Given this list of marker genes SLC29A3, RAB31, SNHG32, SCD, TNFSF13, AKR1A1, CAPG, RNASE1, ITGB2, CYFIP1, QSOX1, MAN2B1 (NCBI Gene Id 4125), CHST15, C1S, ENPP2, ITGAM, LILRB4, PIK3IP1 (NCBI Gene Id 113791), ENG, CCL18, RBM47, QPRT, BCAP31, KRT2, PMP22, KMO (kynurenine 3-monooxygenase), CYP1B1, AVPI1, CCL13, HK3, FGL2, ACVR1B, TSPAN4, NR1H3, SMARCD3, ASPH, GALNT12, CTBP2, HCK, RGL1, IFI30, HLA-DMB, CREG1 (NCBI Gene Id 8804), ZNF22, TMEM51, SLC2A6, SLAMF8, TNS3, FGR, LY96, CAT, CTSL (cathepsin L), OSBPL1A, FCGR2C, CD63, CYP27A1, TM6SF1, CHN2, LPL, FPR3, RASGRP3, C1QA (NCBI Gene Id 712), LAMC1, TBC1D1, KIAA0930, APMAP, IGSF6 (immunoglobulin superfamily member 6), NLRP3 (NLR family pyrin domain containing 3), CTSC, ITSN1, PLAU, FZD2, ARHGEF10L, CTSB, S100A8, TCN2, FTL, CRABP2, CDKN1A, IDH1, ACSL1, SPP1, SLC31A2, FKBP9, GRN, CD14, GFOD1, LHFPL2, GPX1, RAB13, FADS1, PYGL, CEBPA, SLC27A3, INHBA, HLA-DRA, PLA2G1B, ITGAX, RTN1, SIGLEC9, CCR1, GLUL, S100A9, SPARC, EFHD1, ANPEP, TREM2, SIRPA, TFEC, SLC38A6, SLC7A7, AHCY, CYP7A1 (NCBI Gene Id 1581), FUCA1, LIPA, BLVRB, CSF1R, C1QB, PLXND1, MAOA, TAF4, TMEM176B, PILRA, NPC2, LAMP2, VAT1, ADORA3, C2, PAPSS2, PDGFC, APBA2, TSPAN3, SLC20A1, RIPK2, GSN, AK5, CLEC10A, AQP9, RHOQ, ARHGAP22, SCPEP1, RNF144A, ABCB4, CD9, FCGRT, TFPI, TYROBP, MAP2K6, H2BC12, APLP2, TLR1, FCGR2A, APOC1, SHTN1, C1orf54, HMOX1, CTSA, BACE1, ITGB5, FBP1, MERTK, CEBPB, ST14, LPAR6 (NCBI Gene Id 10161), STOM, PLEKHB1, TIMP2, CLEC7A, TGFBR1, STEAP3, MNDA, MRC1, PLBD1, MPZL1, LMNA, PPFIBP2, SORT1, TUBB6, CTSZ, ACOT7, MS4A4A, ECHDC3, NRP1, FABP4, RNF130, CA2, NAGA, MYOF, CD163, PALLD, LGR4, GLA, SYK, CD33, PSAP, SLC15A3, TP53I3, CD86, PLPP3, LDLRAP1, here is a description of the gene set: from publication Prots I, Skapenko A, Lipsky PE, Schulze-Koops H (PMID 21347372) Genes down-regulated in comparison of CD25+ regulatory T cell (Treg) treated with IL4 at day 10 versus CD25- T cells treated with IL4 at 10 h. studied in species Homo sapiens CD25+ regulatory T cells develop in the thymus (nTregs), but may also be generated in the periphery upon stimulation of naive CD4 T cells under appropriate conditions (iTregs). The mechanisms that regulate the generation of peripheral iTregs are largely unknown. We used microarrays to gain insights into the molecular program of extrathymic Treg development. Human Gene Set: GSE24634_TREG_VS_TCONV_POST_DAY10_IL4_CONVERSION_DN